Given this list of marker genes ABCD1, NTSR1, FBP2, MOB4, SERPINB13, BRSK2, CAPN9, CXCL2, HMGCS2, MID1, CLDN3, IGLL1, CCL23, ATP7B, GULP1, PADI2, RARS1, TACR1, HYAL3, DSG1, ARFGEF2, E2F1, TRIOBP, UGT8, COQ7, VAT1, NR2F6, SYDE1, CFD, PLG, PTPRR, PTPRT, DDN, POLA2, CD1E, COL16A1 (collagen type XVI alpha 1 chain), CEACAM5, RTN2, IL5 (NCBI Gene Id 3567), ZBTB5, IL6R, NR1I2, RNASE2, DAPK2, CRISP3, CCN1, TMEM8B, LY9, IMPG1, GABRB2, SNX3, ORC3, GRP, KHDRBS3, TMPRSS2, LPXN, PHACTR1 (phosphatase and actin regulator 1), ADGRE5, BHMT, STEAP1, VENTX, BMP10, MAGEC1, IRX5, GRB7, SLC38A10, VAC14, PDZK1, SRRD, EDNRA, SMPDL3B, MVK, INPP1, TFPI, CHST7, MAP3K3, HOXB5, RELN, CD101, SLC12A4, SEL1L, EPHB6, NR4A1, MNDA, FRK, TCEA2, RTF1, ZNF169, RFPL3S, SIM1, GML, BCHE, ZNF85, DNAJB12, DENND2B, PTPN14, DDIT4, ASMT, INSIG1, PSEN1, CCL1, IL13RA1, DDX6, TOB2, TNFSF14, PPM1E, PPP1R3C, IRX3, FGFR4, C14orf132 (chromosome 14 open reading frame 132), ID3, SCARF1, GJA4, FKTN, HDAC9, DUSP7, PXN, GSE1, GGT5 (NCBI Gene Id 2687), CXCL3, GRIA3, TOX3, ARSL, RGS11, B3GAT2, FXN, RAB40C, LAMA3 (laminin subunit alpha 3), GCA, EPB42, PCDHA12, HTT, IL10RB, PLTP, TLR5, SMOX, PTPRU, COL8A1, SH3BP2, HP, TNFRSF1B, ACACA, SLC7A4, ACTN3, GNAQ, KRT4 (keratin 4), TLX2, MB, GPR68, MFAP5, DMXL2, ZNF165, NTS, STAR, BPHL, CCR9, PIAS3, DUSP5, NUDT13, MYT1L, PCSK6 (NCBI Gene Id 5046), PNP, LORICRIN, DKK3, NID2, EXOC6B, OVOL3, GP9, BARD1, ABCG2, LASP1, IFIT1, PTHLH, SLCO1B1, SIX6, SERPINI1, CDK19, OLIG2, ANK1, PODXL, ABCC8, ATP6V1G2, TNFSF9, NR0B2, XIAP, IFNGR2, RHOC (ras homolog family member C), ATP2A1, KCND3, TPBG, ITPR3, CCN2, TGIF1, BICD1, CSNK2A2, GPM6A, GABRP, ELK3, here is a description of the gene set: studied in species Homo sapiens Since the role of cord blood (CB) regulatory T cells (Tregs) for the suppression of the allogeneic T-cell response is under investigation, we analyzed and compared the functional properties and gene expression profile of Tregs expanded from CB units or from the peripheral blood (PB) of helathy donors. Tregs were purified from 23 CB units and from the PB of 13 donors and expanded for 6 days with anti-CD3, anti-CD28 and IL-2. Immunophenotypic analyses were performed, and suppressor activity of expanded Tregs was measured in mixed lymphocyte reaction (MLR) cultures. The IL-10 production capacity was tested and gene expression profile experiments were performed on 6 Tregs from PB and 4 from CB. CB and PB Tregs had similar immunophenotypic features. Tregs from CB presented a higher expansion capacity and genomic characterization showed in CB-derived Tregs a significant enrichments of genes involved in cell proliferation, chromatin modification and regulation of gene expression in CB-derived Tregs. All samples were positive for the Foxp3 gene and protein after expansion. CB and PB expanded Tregs exerted a comparable and potent suppressive function of MLR and presented a high in vitro IL-10 production capacity. Gene profile analysis also revealed for PB Tregs a significant enrichments of genes involved in the adaptive immune response. Human Gene Set: GSE22501_PERIPHERAL_BLOOD_VS_CORD_BLOOD_TREG_UP Genes up-regulated in T reg from: peripheral blood versus cord blood. from publication Torelli GF, Maggio R, Peragine N, Chiaretti S, De Propris MS, Lucarelli B, Screnci M, Mascolo MG, Milano F, Iori AP, Girelli G, Guarini A, Foà R (PMID 21732086)